The following is a description of a gene set: Human Gene Set: HP_PATENT_DUCTUS_ARTERIOSUS Patent ductus arteriosus species: Homo sapiens In utero, the ductus arteriosus (DA) serves to divert ventricular output away from the lungs and toward the placenta by connecting the main pulmonary artery to the descending aorta. A patent ductus arteriosus (PDA) in the first 3 days of life is a physiologic shunt in healthy term and preterm newborn infants, and normally is substantially closed within about 24 hours after bith and completely closed after about three weeks. Failure of physiologcal closure is referred to a persistent or patent ductus arteriosus (PDA). Depending on the degree of left-to-right shunting, PDA can have clinical consequences., and this is the list of marker genes: SHANK3, IFT56, NADSYN1, NOTCH2, PRDM13, ALG12, ERF, KAT6B, AGGF1, CACNA1C, COL18A1, SKI, MYLK, HACD1, XRCC2, WBP4, PIGA, TMEM94, GLB1, ZBTB7A (NCBI Gene Id 56976), KCNH1, MYCN, THSD1, RAC1, SOS1, KCNN3, RIT1, NKX2-5, GJA5, ERCC4, MAD2L2, SIX6, SKIC2, MAP3K7, TGFBR1, GJA8, NAA20, BMPR1A, SALL1, SMARCA4, STX5, PAK2, AGO2, KMT2B (NCBI Gene Id 9757), VPS33A, MKKS, PCGF2, SNRPB, ARID1B, SMARCC2, BPTF, FUT8, PPFIBP1, UMPS, GATA4, HSPG2, OCLN, SMC5, HDAC4, CSGALNACT1, WDPCP, KMT2D, KCNE5, IPO8, PLXND1, TBX4, RBP4, CALM3, STX1A, FANCF (FA complementation group F), KMT2A, POLR1D, PRKG1, FTO, FGF10, MYH11, BRIP1, FANCA, BRCA1, FANCE, ABCC9, APC2, UBE4B, WAC, TFAP2B, FANCG, MED12, IGBP1 (NCBI Gene Id 3476), EXT2, DAW1, PTEN, TRRAP, TBX5, LMX1B, DYRK1A, GATA6, SF3B4, FKBP6, KAT8, PIK3CA, TKT, ACTB, EP300, UFC1, STXBP1, EOGT, SSR4, SEMA3E, TRPV6, EED, RSPRY1, TWIST1, HTRA2, ACTA2, FOXE3, HPGD (15-hydroxyprostaglandin dehydrogenase), PIGT, IFT27, NEDD4L, STAG2, SF3B2, SUCLG1, SOS2, TRAF7, ZMPSTE24, RPS26, TRIO, FANCC, KANSL1, RAD51, TBX2 (T-box transcription factor 2), TMEM270, CHD4, NKX2-6, CEP120, FOXC2, MYRF, FANCI, MID1, BCOR, GLI3, ARSL, SNX14, ZEB2, LMBRD1, MRAS, SMARCE1, ZMYM2, ARID1A, VPS37D, NFIX (NCBI Gene Id 4784), GNA11, TALDO1, CUX1, NRAS, UBE2A, PRDM16, GTF2IRD2, DNAJC30, TGFBR2, PEX1, FANCL, GLYCTK, TGFB2, ADAMTS17, TBC1D24, IGF2, MYOCD (NCBI Gene Id 93649), ARF1, ERMARD, USP18, SEC24C, GTF2IRD1, TMCO1, FOCAD, HYMAI, METTL27, NOTCH3 (notch receptor 3), AXIN1, TMTC3, FBN2, SLX4, PIGN, DMPK, CREBBP, EIF4A2, SMC3, MMP23B, RAD51C, CTCF, LZTR1, PACS1, THSD4, DPM1, FOXP2, CCDC22, COMT, BRCA2, DTNA, LTBP2, ARVCF, ALG8, SPECC1L, SMARCA2, PALB2, ARID2, FRA10AC1, NONO, JMJD1C, SLC25A24, EBF3, COG6, COQ4, PTPN11, FBN1, GJA1, NAA10, ALB, DHCR7, PCNT, CIROP, ANK1, PRDM6, FKBP14, SON, GTF2I, UBR7, NIPBL, PSMD12, RFC2, NCF1, ASCC1, TBL2, TBX1, MFAP5, RAF1, PRIM1, FGFR3, BUD23, SIK3, GPC3, CDC42BPB, PLAGL1, TRIP11, SMAD2, SOX4, DHCR24, AMMECR1, TCOF1, PRKCZ, MASP1, ANKS6, RRAS2, DPF2, KRAS, SPEN, ECE1, HEY2, BRAF, WDR35, MYH7, FBXL4, CBL, EHMT1, KAT6A, GP1BB, NODAL (nodal growth differentiation factor), RREB1, PEX19, SMARCD1, SUPT16H, UBE2T, MAF, HIRA, PLCB3, AMER1, MCTP2, USP9X, SMARCB1, SKIC3, LARS2, RERE, CTU2, DDX3X, BAZ1B, POLR1C, RAP1B, FOXF1, NPHP3, ZNF699, SLC29A3, DNMT3A, MEGF8, KDM6A, FANCM, WT1, FANCB, LUZP1, CHRM3, POGZ, GABRD, PPP1CB, LMNA, MAPKAPK5, B3GLCT, PORCN, CDC42 (cell division cycle 42), KCNJ8, TSFM, DYNC2LI1, SALL4, MAT2A, LOX, FGFR2, RBM8A, SAMD9, CHD7, AFF4, ZFX, FANCD2, PHGDH, GPC4, ARX, RASA2, C2CD3, CCDC47 (NCBI Gene Id 57003), ADAMTS10, ADAT3, ABCD4, THOC6, RPL5, ARL6IP6, ARFGEF2, MGAT2, DVL3, NCAPG2, DACT1, ASXL2, CASZ1, EIF4H, SMAD4, POLR1B (NCBI Gene Id 88998), KCNAB2, NSD1, MAP1B, PUF60, EZH2, ATP6V1E1, POLR1A, DNAH9, WLS, SNRPN, ESCO2, ZMIZ1, WDR37, COA6, YY1AP1, TGFB3, ELN, CEP295, KYNU, CLIP2, UFD1, SOX2, SOX11, ACSL4, FLNA, MAP2K1, TP63, G6PC3, STRA6, ZNF148, PDPN, RFWD3, SPRED2, RPL11, SMAD3, MKS1, RRAS, LIMK1, RAB23, TRIP4 (NCBI Gene Id 9325), FOXC1, CD96, MED11, ZIC3, CADM3, MRPS16